The following is a description of a gene set: Red eye A reddish appearance over the white part (sclera) of the eye ranging from a few enlarged blood vessels appearing as wiggly lines over the sclera to a bright red color completely covering to sclera. studied in species Homo sapiens Human Gene Set: HP_RED_EYE, and this is the list of marker genes: PLG, HLCS, RNF113A, FBN1, IL12A, TNFRSF13C, IL12A-AS1, TP63, ERCC4, CD79A, IKZF1, UBAC2, WIPF1, MEFV, BLNK, MAB21L1, CD79B, HLA-DRB1, STX16, GMPPA, ZFX, UROS, ERF, TFRC, IGHM, CR2, IFNGR1, TNFRSF13B, GTF2H5, MPLKIP, PAX6, AAAS, SHMT2, FOXC1, SMCHD1, DUX4, CCR1, KLRC4, GJB2, STX11, TNFRSF1A, AP1G1, TLR4, GTF2E2, DUX4L1, VPS33A, ERCC6, MAPT, TCF3, FOXC2, IGSF3, BTK, ERCC8, ERCC3, UROD, PTPN22, FGF10, LRRC8A, GSN, AIRE, FGFR2, SCN9A, BTD, IARS2, ATP2A2, FGFR3, SAMD9, RAG1, NLRP3, FRG1, SLC39A4, PIK3R1, DDB2, C4A, COL17A1, RNF125, PSMB4, DKC1, XPC, ICOS, PSMB8, FERMT1, TARS1, AEBP1, CD19, TKT, GNAS, POLH, ERAP1, COL7A1, WAS, DNASE1L3, RECQL, USB1, FAS, CARS1, TRAPPC11, SLC39A7, SREBF1, LYZ, AP1B1, HLA-B, ERCC2 (NCBI Gene Id 7269), AARS1, MTTP, NOD2, GATA1, RAG2, LRBA, TRIM44, LBR, NLRP1, IL23R, MBTPS2, XPA, STAT4, BTNL2, TBK1, GJB6, IL10, IGLL1, PAX1, KAT6A (lysine acetyltransferase 6A), SPI1, DNMT3B, ERCC1, LYN, TGFBI